The following is a description of a gene set: Genes up-regulated in peripheral blood mononuclear cell 7d vs 0d in adults after exposure to Inactivated influenza vaccine, time point 7D. Comment: Up-regulated DE RNA transcripts (up >= 1.5x) shared between both TIV-vaccinated donors Human Gene Set: HOEK_PBMC_INACTIVATED_INFLUENZA_ADULT_7DY_UP studied in species Homo sapiens Systems biology is an approach to comprehensively study complex interactions within a biological system. Most published systems vaccinology studies have utilized whole blood or peripheral blood mononuclear cells (PBMC) to monitor the immune response after vaccination. Because human blood is comprised of multiple hematopoietic cell types, the potential for masking responses of under-represented cell populations is increased when analyzing whole blood or PBMC. To investigate the contribution of individual cell types to the immune response after vaccination, we established a rapid and efficient method to purify human T and B cells, natural killer (NK) cells, myeloid dendritic cells (mDC), monocytes, and neutrophils from fresh venous blood. Purified cells were fractionated and processed in a single day. RNA-Seq and quantitative shotgun proteomics were performed to determine expression profiles for each cell type prior to and after inactivated seasonal influenza vaccination. Our results show that transcriptomic and proteomic profiles generated from purified immune cells differ significantly from PBMC. Differential expression analysis for each immune cell type also shows unique transcriptomic and proteomic expression profiles as well as changing biological networks at early time points after vaccination. This cell type-specific information provides a more comprehensive approach to monitor vaccine responses. from publication Hoek KL, Samir P, Howard LM, Niu X, Prasad N, Galassie A, Liu Q, Allos TM, Floyd KA, Guo Y, Shyr Y, Levy SE, Joyce S, Edwards KM, Link AJ (PMID 25706537), and this is the list of marker genes: HERC2P3, IGLL5, TRBV30, IGLV2-14 (NCBI Gene Id 28815), OLMALINC, IGLV3-21, CXCR3, BHLHA15, IGHG1 (immunoglobulin heavy constant gamma 1 (G1m marker)), IGHG3, IGLV1-44 (immunoglobulin lambda variable 1-44), IGLC1, IGLV3-19, IGHV1-58, CPXM1, SLX1A, DEPTOR, CTSG (NCBI Gene Id 1511), IGLV2-18, UPK2, IGHG2, SULT1A3, SFRP5, IGHV3-20, GTF2H2C, TRAV38-1, IGHV1-69, MEF2C-AS2, DNAI2, IGLJ3, IGHV1-46, STX1B, HBA1, IGHV2-26, HSD11B1L, IGLV1-36, IGHV4-39, IGHG4, IGLC2, IGHJ2, IGHV6-1, IGLV3-1, ALAS2, TMEM121, IGLC3, C22orf15, IGLV1-51, IGHV3-7, NT5DC2